Given this list of marker genes Ep400, Shld1, Phf10, Spidr, Ube2v2, Rnf8, Morf4l2, Ing3, Ruvbl1, Bcl7a, Pbrm1, Epc2, Actl6b, Meaf6, Ddx11, Ercc6, Dpf2, Setmar, Fh1, Slf2, Arid1a, Hdgfl2, Smarcd2, Wdr48, Sirt6 (NCBI Gene Id 72769), Smarcd3, Rad51ap1, Smchd1, Trrap, Shld3, Pnkp, Mre11a, Crebbp, Blm, Zcwpw1, Sirt1, Morf4l1, Epc1, Smarca4, Brd7, Yeats4, Peli1, Spire2, Mad2l2, Parp1, Ager, Dpf3, Helq (NCBI Gene Id 338528), Smarcd1, Brd8, Smarce1, Kat5, Smarcb1, Smarcc1, Spire1, Foxm1, Was, Dmap1, Skp2, Top2b, Fmn2, Bcl7c, Atm, Fus, Arid2, Vps72, Bcl7b, Kmt5b, Ube2n, Parp3, Fancb, Wrap53, Cyren, Mgmt, Shld2, Ooep, Ruvbl2, Kdm4d, Mrnip, Smarca2, Khdc3, Timeless, Prkdc, Smarcc2, Actl6a, Dpf1, Mrgbp, Pias4, Rif1, Actr2, Actb, Mbtd1, Slf1, Prmt1, Rnf126, Kmt5c, Nbn (nibrin), here is a description of the gene set: species: Mus musculus Mouse Gene Set: GOBP_POSITIVE_REGULATION_OF_DOUBLE_STRAND_BREAK_REPAIR Any process that activates or increases the frequency, rate or extent of double-strand break repair.